The following is a description of a gene set: Intrauterine growth retardation Human Gene Set: HP_INTRAUTERINE_GROWTH_RETARDATION An abnormal restriction of fetal growth with fetal weight below the tenth percentile for gestational age. studied in species Homo sapiens, and this is the list of marker genes: BCR, WARS2, FAM20C, MRPS28, LYN, NDUFB7, POT1, CEP290, SF3B4, DEF6, SEC31A, PALB2, BBS2, B3GLCT, NODAL, LONP1, GATAD2B, SEC24C, NBN, NUP188, RFX6, SLC35C1, RECQL4, PTCD3, DCLRE1B, UBE2T, MKRN3, EVC2, PTPN11, MCM4, NDUFS1, CDC42BPB, HMGA2, NSDHL, FOCAD, EIF5A, CTSK, MPLKIP, EPB41L1 (erythrocyte membrane protein band 4.1 like 1), TUBGCP4, DNAJC19, QRICH1, NDUFAF3, CHD7, POP1, OTUD5, FOXP2, NFIX, FIG4, OSGEP, IBA57, QRSL1, GFM2, FANCG, NDUFAF1, STN1, KIF14, DPP9, GUF1, ASCC3 (activating signal cointegrator 1 complex subunit 3), CANT1, DISP1, UQCRFS1, SIX3, ALDH18A1, CTBP1, STAT3, PRKACA, POLA1, TRAIP, TGDS, TCTN3, SLC25A24, ZBTB18, TBX1, ABCD1, VPS13B, TRMT10A, GP1BB, LRRC32, MCTP2, PRKAR1A, PWRN1, FANCA, TOP3A, FBN1, HERC2, COG6, LAMA5, NPM1, ABCC8, ELN, SHQ1, MYORG, RAC1, NDUFS3, RELN, RHCE, NUP88, POGZ, ADGRG1, ABCB7, CHRND, ATP5F1A, DNAJB4, PDE4D, GMNN, XYLT1, PYCR1, INS, C1QBP, BCS1L, TYMS, CDK10, RBM10, DHCR7, NIN, NDUFA6, GNA11, FTO, HNRNPC, COX11, SRPX2, ATRIP, PLOD3, PRKACB, PUF60, PTDSS1, NRCAM, KMT2D, WDR73, AARS1, CITED2, LARS2, BRPF1, MT-ND1, GLIS3, FDFT1, GLDN, KLF11, STRA6, APPL1, EVC, DYRK1A, RNU4-2, SUFU, MKS1, UFD1, SLC30A9, GTF2H5, SUCLG1, TRIM37 (tripartite motif containing 37), CRKL, PEX5, ADGRG6 (adhesion G protein-coupled receptor G6), HES7, TRAPPC11, NDUFAF8, MT-ND2, PLK4, ARID1B, PSAT1, PSPH, MBTPS2, SMARCA4, XPR1, MADD, MT-ND3, SAMD9, NAA10, FLT4, ACD, SEMA3E, CEP295, DNAJC21, ZNF699, USB1, TBC1D20 (TBC1 domain family member 20), NDUFS4, TIMM22, PLAG1, COG1, SON, PET100, SKIC3, KAT6A (lysine acetyltransferase 6A), TSFM, TAF1, FBLN5, NEUROD1, GDF1, TRAF7, RHD, TERC, RMRP, FUT8, GTPBP3, ATP6V1A, CORIN, CDC6, ZPR1, RTEL1, CDC45 (cell division cycle 45), OBSL1, LMBRD1, LEMD2, CTDP1, UBAP2L, GBA1, RFWD3, NUP133, STOX1, AHDC1, RTTN, CTU2, COX6B1, NDUFS7, BLM, ELAC2, TAF6, GRB10, POLE, HBB, BLK, WNT4, DHDDS, SMARCA2, UBR1, UBE3C (ubiquitin protein ligase E3C), FOXRED1, FZR1, CEL, PRDM13, GATB, NF1, ERCC3, STT3B, SC5D, SFXN4, SIX2, PDX1, RAB3GAP1, MYH3, MTHFR, POLR1A, CKAP2L, ERCC6, MEG3, COQ4, CENPE, DOK7, ARPC5, SMARCC2, SPTBN1, ASXL3, NDUFS2, ALX4, CDKN1C, YRDC, EXOSC9, ALG8, IGF1R, PCGF2, TUBA1A, MRPS25, MAD2L2, FGFR1, HADH, PIK3R1, ARID2, RIPK4, ASXL1, ERI1, RAD51C, CEP57, RNF113A, ADNP, RNU4ATAC, RARB (retinoic acid receptor beta), PDHA1, SEC24D, RNASEH2A, SLX4, DNMT3A, PHGDH, DST, AFF2, GON7, NSD2, USP9X, GFM1, TFAP2A, DDX3X, GAS1, TARS1, FLT1, MCM5, ZIC2, SMARCB1, COQ9, NDUFB10, RB1, NUS1, SDHA, NDUFA10, CNOT1, TTC7A, TONSL, WNT7B, MYOD1, ASNS, RREB1, NDUFB11, RPL11, TALDO1, MED12 (mediator complex subunit 12), HYMAI, GPKOW, FANCM, CDT1, SEMA5A, TIMMDC1, KDM6A, PRMT7, RTL1, PTCH1, GINS1, NEK9, HHAT, HNF1A, LMNA, SLC35A2, RAD51, COMT, NDUFA11, FLNB, AMFR, MYT1L, STAG1 (STAG1 cohesin complex component), MT-TL1, GLI2, SIN3A, ALG1, MTRR, TERT, CDK13, TRIP13, RBBP8, SMPD4, LIFR, SMC3, IDH1, RAB3GAP2, RAD21, NUP107, VANGL2, LFNG, FRA10AC1, PWAR1, SOX4, CCDC134, RPL10, NPAP1, UQCC2, IGF1, PKLR, TINF2, ERCC1, SHH, SLC25A13, NOS3, WDR4, PLAGL1, FMR1, FOSL2 (NCBI Gene Id 79579), SMC1A, TUBGCP6, HSD11B2, DDX11, CDCA7, ADAT3, LIG4, GATA4, CWC27, ACADS, TMEM70, FANCD2, XRCC2, SKIC2, WASHC5, PAX4, P4HB, UNC80, NDUFAF2, COQ7, TBCE, ZFP57, CLCN7, PLXND1, CRIPTO, AUTS2, PCDH12, RNU7-1, STT3A, ARL6IP6, TOR1A, SMARCE1, CARS1, PI4KA, IGF2, CCNQ, CTC1, KATNB1, ZMPSTE24, ITPA, DHCR24, ATP7A, ASXL2, SMAD4, JAM2, MESP2, DBR1, NELFA, KIF5C, FGF8, PCNT, NADK2, ATP6V1E1, OTUD6B, WRAP53, SMARCD1, SLC18A3, RAF1, RIPPLY2, FOXH1, SV2A, BIN1, EP300, TGIF1, XRCC4, ORC4, NALCN, IFIH1, GJA5, INSR, SLC26A2, CUL7, KDR (kinase insert domain receptor), RPS19 (ribosomal protein S19), NDUFV2, SLC20A2, BUB3, LAGE3, POLR3A, NDUFAF4, MESD, KMT2B, MTO1, NDUFB9, BRIP1, LEMD3, NFE2L2, GATA5, PDGFRB, PDHB, EFEMP2, FANCF, H19, KMT2A, HYLS1, PIGG, DNA2 (DNA replication helicase/nuclease 2), BUB1, KCNJ11, ABL1, INTS11, SCO2, ZMYM2, PRORP, SNRPB, TFAM, YIF1B, BRCA2, ATR, TP53RK, GLI1, PIEZO2, FANCB, SNRPN, ZFPM2, MUSK, CLPB, LETM1, COX16, NDUFAF5, NSUN2, SMARCAL1, SDHAF1, DLL1, KANSL1, CREBBP (CREB binding protein), BCAP31, NDUFA1, HNF4A, TBX6, SDHD, NUAK2, COG5, BRCA1, HDAC8, ARID1A, GATA6, JMJD1C, FLI1, FGFRL1, FANCC, ESCO2, ALG12, IARS1, CEP152, JUP (junction plakoglobin), COG4, KIF21A, BMPER, TPRKB, COG8, ERCC2, PRIM1, TMEM126B (transmembrane protein 126B), SNORD115-1, ARCN1, YY1, PAH, WNT7A, ADAR, ZNF335, DRG1, SATB1, NDUFS8, NDUFV1, HDAC6, JAG1, NCAPG2, PTF1A, RHAG, SDHB, RAB18, RNF2, CTNND2, FANCL, RERE, SCUBE3, DYNC2LI1, CENPJ, CHRNG, SOX11, ATP6V0A2, ERCC5, LTBP1, FLVCR2, MAPK1, NDUFB3, IGHMBP2, CDON, FAM111A, BRAF, TUFM, SCO1, HIRA, DLL3, SEC61A1, CHRNA1, GCK (NCBI Gene Id 2645), PPP2R5D, PARN, NOP10, NKX2-6, RAPSN, PNPT1, FANCI, NIPBL, ARVCF, GLB1, NDUFS6, DONSON, NKX2-5, TMEM216, CPLX1, DPF2, BRD4, EMG1, ERCC4, MAGEL2, GTF2E2, NUBPL, DSP, ORC6, TBX4, DKC1, CRTAP, SNORD116-1, GNAS, PRPS1, SLC30A7, MMACHC, KIF2A, ERCC8, FANCE, TELO2, COG7, DLK1, NHP2, IL6ST, FKTN, NDE1, PPP1R15B, GLI3, PEX2, PRKDC, TAPT1, HOXD13, FARSB, BUB1B, GATC, ORC1, MLXIPL, NUP85, PDGFB, MED11, CCDC8, PDE6D (NCBI Gene Id 5147), PUM1